The following is a description of a gene set: This event has been computationally inferred from an event that has been demonstrated in another species.<p>The inference is based on the homology mapping from PANTHER. Briefly, reactions for which all involved PhysicalEntities (in input, output and catalyst) have a mapped orthologue/paralogue (for complexes at least 75% of components must have a mapping) are inferred to the other species. part of: N-glycan antennae elongation in the medial/trans-Golgi Reactome Pathway: N-Glycan antennae elongation electronically inferred by orthology from the curated human pathway species: Mus musculus, and this is the list of marker genes: Mgat4c, St3gal4, St8sia3, B4galt6, St8sia2